Given this list of marker genes GLRA1, ALDH1A3, FOXP2, SLC1A1, SHANK1, NPSR1, AFG3L2, GLRB, USP46, here is a description of the gene set: A reflex process in which an animal immediately tries to turn over after being placed in a supine position. studied in species Homo sapiens Human Gene Set: GOBP_RIGHTING_REFLEX